Given this list of marker genes ESCO2, EXOC2, LETM1, CEP290, LTBP4, B9D1, FGFRL1, RPGRIP1, PRIM1, TCTN1, YARS1, NSD2, MYCN, CENPF, TCTN3, WT1, TMEM231, ATP6AP1 (NCBI Gene Id 537), TCTN2, HYLS1, EP300, TXNDC15, CREBBP, RPGRIP1L, CC2D2A, TMEM216, CPLX1, B9D2, TMEM237, MKS1, MYRF, CTBP1, TMEM67 (transmembrane protein 67), CSPP1, TMEM107, PPP2R3C, here is a description of the gene set: Accessory spleen Human Gene Set: HP_ACCESSORY_SPLEEN studied in species Homo sapiens An accessory spleen is a round, iso-echogenic, homogenic and smooth structure and is seen as a normal variant mostly on the medial contour of the spleen, near the hilus or around the lower pole. This has no pathogenic relevance.